The following is a description of a gene set: Mouse Gene Set: chrXA2 species: Mus musculus, and this is the list of marker genes: Gm5124, Tesl2, Wdr44 (WD repeat domain 44), Gm10058 (NCBI Gene Id 100039240), Gm5168, Slx, Gm10230, Gm5935, Slc6a14, Gm9440, Gm14562, Gm4297, Gm6938, Gm7386, Gm7375, Gm4732, Gm26131, Gm14561, Gm6121, Gm4789, Gm2003, Gm6956, Gm6113, Gm14563, Tesl1, Gm14525, Gm2030, 4930453H23Rik, Gm15030, Gm2117, Klhl13, Gm2759, Gm2768, Gm7350, Gm2005, Gm5934, Gm24535, E330010L02Rik, Agtr2, Gm5169, Gm28269, Gm6071, Gm9439, Ppp1r2-ps7, Gm54077, Gm25812, Gm2101, Gm7164, Gm2012, Gm1993, Gm7365, Gm22592